The following is a description of a gene set: from publication Chen Y, Wang X (PMID 31504780) species: Homo sapiens Human Gene Set: MIR514A_3P_MIR514B_3P Genes predicted to be targets of miRBase v22 microRNA hsa-miR-514a-3p, hsa-miR-514b-3p in miRDB v6.0 with MirTarget v4 prediction scores > 80 (high confidence targets)., and this is the list of marker genes: FHAD1, BBIP1, ZNF675, JAK1, TCF12 (NCBI Gene Id 6938), SCN3A, SRGAP1, PTEN, EGFR, MS4A3, JAM2 (junctional adhesion molecule 2), SYT11, PSMA2, GUF1, CAPSL, ERC1, RBM27, HELZ, FAM117A, CHD7, NFIB (NCBI Gene Id 4781), PPP2R1A, PCCA, MVB12A (NCBI Gene Id 93343), PRKD1, RABEP1, DCAF10 (DDB1 and CUL4 associated factor 10), SNIP1, SUCLG2, BAALC, HIPK3, ATP8B1, REPS2, GTF3C4, VGLL3, LRAT, PCNP, NRXN3, RAB3A, ZNF474 (NCBI Gene Id 133923), ETNPPL, CD200R1, SESN3, RNF19B, COL2A1, DLK1 (NCBI Gene Id 8788), EML6, QSER1, SPDYA, C20orf203, CARMIL1, NCOA7, HECTD2, FAM8A1, DCLK3, PPP1R12A, LPAR4, PEG3, ADGRL4, RFT1, ARHGEF9, BTBD1, USP27X, PIK3C2B, KHDRBS1, CENPC (centromere protein C), PPIL4, STAM2, SSH1, ZFHX3, PTPRG, FNTB, GULP1, SVIL, TMX4, CUL2, STARD7, ITCH, TSPAN9, ZNF257, MBTD1, CABLES1, TBCA, DEFB132, VCPIP1, CLGN, RBX1, TMEM68, ZNF350, ANO5, SPRY4, AVIL, TPR, BCAP29, AGO4, ZNF800, NPAS3, TMEM50A, NEXMIF, SLC35D3, KCTD1, TAC1, ZNF282 (NCBI Gene Id 8427), ECE1, SPO11, AFDN, AFF4, C7